The following is a description of a gene set: from publication Chen Y, Wang X (PMID 31504780) studied in species Homo sapiens Human Gene Set: MIR6779_3P Genes predicted to be targets of miRBase v22 microRNA hsa-miR-6779-3p in miRDB v6.0 with MirTarget v4 prediction scores > 80 (high confidence targets)., and this is the list of marker genes: LRIG1 (leucine rich repeats and immunoglobulin like domains 1), BDKRB2, ZNF518A, FBXO4, MIB1, PAK2, BRK1 (BRICK1 subunit of SCAR/WAVE actin nucleating complex), PTPRG, SMARCAD1, ITPKB, MEMO1, ITSN2, TNPO3, FRAT1, TIPARP, RFX3, JOSD1, TLCD5, DNAL1, PHTF2, DNMT3B, PRDM2 (PR/SET domain 2), ZC3H7B, NUP98, KLHL4, RILPL1, PLEKHH1, SIN3A, ZDHHC15, MAMDC2, RREB1, TMEM47, SLC2A10, UBE2V1, TRIB1, KCNK10, SLC24A2, CAMK2N1, SAE1, PPIF, CHST12, SEC14L1, FAM220A, PARD6B, ZBTB34, SEC63, RNFT1, RGS21, ZNF516, CLASP2, CACNA1E, SLC4A4, RIPOR1, PPM1D, SKIDA1, KRT15, KDM7A, CDK2, RASGRF2 (Ras protein specific guanine nucleotide releasing factor 2), DCAF7, CDHR1, PIEZO2, DDX31, ESRP2, SMNDC1, NAV2, DGKI, ADAM23, ZNF605